The following is a description of a gene set: Genes down-regulated in primary bronchial epithelial cells: control versus stimulated with IL22. Primary HBE cells were stimulated with IL-22 and IL-17, and gene expression was studied using an Affymetrix platform microarray, in order to investigate which genes may be upregulated or downregulated in response to these cytokines. Of particular interest was the host defense genes such as antimicrobial peptides, which have been shown to be upregulated by IL-22 and IL-17 in skin keratinocytes. species: Homo sapiens from publication Aujla SJ, Chan YR, Zheng M, Fei M, Askew DJ, Pociask DA, Reinhart TA, McAllister F, Edeal J, Gaus K, Husain S, Kreindler JL, Dubin PJ, Pilewski JM, Myerburg MM, Mason CA, Iwakura Y, Kolls JK (PMID 18264110) Human Gene Set: GSE10240_CTRL_VS_IL22_STIM_PRIMARY_BRONCHIAL_EPITHELIAL_CELLS_DN, and this is the list of marker genes: CLDND1, COX5A, ARPC2, ERG28, SIK2, ANAPC16, TAF12, IQCH, MARS2, ZNF14, GRAMD2B, RUFY3, TBL1X, CHST11, C2CD2, ATP6V0B, EMC2, THAP12, GNB1L, IDS, NFKBIE, RANBP10, EFCAB7, ARRDC4, MRPL36, ORAI1, SSBP4, ABHD1, DEK, TRAK2, EHD3, CCNF, SREBF1, RPL17, DDI2, TNKS2 (tankyrase 2), RAP2A, PTPRCAP, NRBF2, EPC2, MMP8 (NCBI Gene Id 4317), GRM4 (glutamate metabotropic receptor 4), PCMT1, EMC1, FHL2, EZH1, RER1, ROCK1, RACGAP1, C10orf88, MAX, FAM220A, CD96, FHIP2A, HOXD9, RTRAF, MLLT3, RASL11B (RAS like family 11 member B), RFX1, DAZAP2, CIAPIN1 (NCBI Gene Id 57039), CPSF3, FANCF, VPS33A, SLC22A14, C11orf86, RIOK3, HCLS1, PRR14, NCBP2, G2E3, ELOF1, AIP, DHX38, MRPS24, MAN2A1, WDR45, SIRT1, RIOX1, EPC1, PPP2R5E, RPL39, USP40, STRN3, MXRA7, TTC14, RPTOR, MED11, NARS2, ATG13, TESK1, ULK3, SLC13A2, NAAA, COQ4, KMT2D, PIR, HSD17B7, RPS11, QKI, PPIP5K1 (NCBI Gene Id 9677), PKD2L2, SLC9B2, GPAM, VPS26C, ZBTB33, PTGES3, EIF1, CAMK2N1, PSMA2, RPS8, MTG1, MTMR1, VAV1, GNB4, ANAPC10, TRPM4, CMIP, TRAF3IP1, QTRT2, MRPL37, SLC30A9, DNAAF5, ENPEP, DNAJB11, LUZP1 (leucine zipper protein 1), FAM219B, RAB35, PPP1R37, MED12, DPP3, NCOA1, CIBAR1, ARMC6, DCUN1D2, CHUK, HMGXB3, ZIC1, IFNGR1, VASP, NXT2, WDTC1, NANS, SCML4, NOXO1, MDM1, SMDT1, SIPA1L1, ERCC6L, ARHGAP25, SETD6, TECPR1, EDIL3, SLC22A15, FICD, BORCS7, ADAM10 (ADAM metallopeptidase domain 10), PLA1A, B3GAT3, NUP93 (NCBI Gene Id 9688), CCNB1IP1, HERPUD2, MYO1H, ARF1, ABI3, ENTPD7, POMP, TAP1, NDUFC1, UBA3, PHF1, WWP2, LRIG2, TRPV2, FKBP1A, ITGA10, F13B, OSBPL11, SLC52A2, TPM3, UBE4A, MEGF9, PPCDC, TRIM41, NME3, HERC2, ZNF800, TMTC1, APEX2, CDK2AP1, ASAP2, ANLN, ATOSA, HPS4, GRIPAP1, DBP, HLA-A, SP1, TASP1, UBN1